The following is a description of a gene set: species: Mus musculus Mouse Gene Set: GOBP_ENDOCARDIAL_CELL_DIFFERENTIATION The process in which a relatively unspecialized cell acquires the specialized structural and/or functional features of an endocardial cell. An endocardial cell is a specialized endothelial cell that makes up the endocardium portion of the heart. The endocardium is the innermost layer of tissue of the heart, and lines the heart chambers., and this is the list of marker genes: Acvr1, Sox17, Nrg1, Notch1, Sox18, Smad4